Given this list of marker genes Epb41l4b, Qki, Cyp2c54, Hspe1, Slc37a1, mt-Nd1, 1810053B23Rik, Sh3pxd2a, Sigmar1, Habp2, Tm4sf4, Rspry1, Midn, Gm18303, Gm10748 (NCBI Gene Id 100038710), Selenok-ps1, Zfp655, Polg, Pik3r1, Gm17935, Lztr1, Slc26a2, Atxn7l3b, Sult2a8, Lats2, Dlat, Mpzl3, Duxf4, 3110009E18Rik, Zfp280d, Canx, Vtn, Ccdc62, Chd3, Gm16120, Lbp, Gm15564, Psme3ip1, mt-Tl2, Lcmt2, Abcb4 (NCBI Gene Id 18670), Kpnb1, Mir1931, Hrg (NCBI Gene Id 94175), Dpyd, Sec11c, A1bg, Pla2g15, Serpina3k, Snord45c, Sumo3, Cyp2b10, Slc1a2, G6pc1, Synpo, 2610203C22Rik, Adal, mt-Th, Hdac5, Zfhx2, Mn1, C230037L18Rik, Gm7289, Tmem11, Cyp2j5, Gm16573, Glyat, Sdc4, Pbdc1 (NCBI Gene Id 67683), Rfc2, Tyw5, Rsad1 (NCBI Gene Id 237926), Cyp2c69, Gc, Slc6a12, mt-Tl1, Gm8883, Chd1l, Ddrgk1, Arhgap23, Sardh, Rnf139, Ugt2b1, Gm15247, Gm23010, Stap2, Adcy10, Aox3, Fam216a, Pbld2, Madd, Tgm2, Fcsk, mt-Nd5, Cnot6, Hsp90ab1, Cog1, Gm16035, 4930502E09Rik, Gm27216, Rabgef1, Gm22863, Knl1, R3hdm2, Slc6a13, Havcr1, Fmo1, Nostrin, Ccser2, Gm7457, Cyp3a13, Tbc1d31, Creb3l1, Pitx3, Fhod3 (NCBI Gene Id 269001), Tef, Ugt1a5, Dna2, Lipc, Svil, St6gal1, Thrsp, Dsc2, Timd2, Tnrc18, Gm2061, Etnppl, Gm12354, Cbx3 (NCBI Gene Id 12417), Ttll11, Gm19705, Antxr2, Zmynd8, Sqor, Smarca4, Gm16116, Gfra1, Ddc, Cyp2c68, Gm11400, Casp8, Cyp2e1, Mis18bp1, Relch, Bnip3, Slc30a9, Gm17597, Mbl1, Gm33050, Ccdc162, 4930447C04Rik, Ppp4r1, Gm22043 (NCBI Gene Id 115489855), Gpn3, D630024D03Rik, Atg7, Adra1b (adrenergic receptor, alpha 1b), Baz2b, Ube2v1, Spryd4, Asb4, mt-Tc, Il4ra, Ss18l1, Tyw1, C9orf72, Fryl, 4930519P11Rik, mt-Ty, Gm37450, Rxrg (retinoid X receptor gamma), Mafg, Dtx1, Gm7463 (NCBI Gene Id 675227), Mat1a, Anapc5, Meis1, Tpd52l2, mt-Ts2, Hnrnpa2b1, Igf2, Serpina3m, Eif3d, Bri3, Proc, Gne, Junos, Zfpm1, Fau-ps2, Gm17196, Pemt (phosphatidylethanolamine N-methyltransferase), Stard4, Tmc1, Ehmt1, 5530601H04Rik, Abcc2, Trim28, Nefm, Mir6981, Gm6506, Prlr, Gm16551, Slc2a2, Myo1b, Usp18, Amacr, Pm20d1, Cul2, Bach2, 2610005L07Rik (RIKEN cDNA 2610005L07 gene), Mocs2, Map2k6, Rgn, Car8, Mical2, Jun, Cops4, Spef1l, Rdh7, 3110070M22Rik, Mapkapk5, Msl2, Cyp2d26, Slc15a5, Agt, Zfp292, Gm3948, Amy1, Btbd10, Gm13017, Cfap20, Tor3a, Itih2, Sp3, Nuak2 (NCBI Gene Id 74137), Prxl2a, Rida, Nck1, Cttn, Asph, Mtarc1, Gm454, Plekhg1, Pign (NCBI Gene Id 27392), Gm22203, Hbs1l, Psma7, Mxra8, mt-Ta, Mgst1, 2500004C02Rik, Hspd1, Sgms2, Arsa, Tle4, Epha2, Or14a257, Map9, Oasl1, mt-Tn, Hnrnph3, 5033403H07Rik, Aldh3b3, Gstm7, Nfia, 1700120K04Rik, Cux2, Rabggtb, Mir6236, Dusp16, Gm7985, Dapk2, U90926, Apcs, 1600014C10Rik, Slc41a2, Ctsc, Gm28564, Tmsb15a, Pcdhgc3, N4bp2, Man2a1, Sdf4, Pygb, Stau1, Pparg, Tedc2, Ptgfr, Rab11a, Slc25a47 (solute carrier family 25, member 47), Eapp, Nup42, Cux1, Cyp2c67, Rhoa, Ubl3, Bcas3os2, Pja1, Nr0b2, Gask1a, Gjb1, Gm14403, Rps6-ps1, Duxf1, Sec16a, Rpl36, Angel2, Gm23819, Vdac1, Rab40c, Mir2139, Platr4, Gm6316, Dbi, Ankrd37, Sfi1, Spata31e2, Prkag2, Gm24494, Acadm, Ptprd, Gm8357, Gm17767, Gm12059, Gm20319, Faf1, mt-Tv, Mideas, Cdk10, Haus3, Elk4, Hbp1, Ank1, Mir5623, Tle1, Mtus1, Leap2, Or2b28, Kansl3, Uroc1, Irf2, Gm14400, Tstd1, Slco1a1, Gm2a, mt-Rnr2, Npsr1, Gm16754, here is a description of the gene set: Genes containing one or more binding sites for (Cux2) in their promoter regions (TSS -1000,+100 bp) as identified by GTRD version 20.06 ChIP-seq harmonization. species: Mus musculus Mouse Gene Set: CUX2_TARGET_GENES from publication Yevshin I, Sharipov R, Kolmykov S, Kondrakhin Y, Kolpakov F (PMID 30445619)